The following is a description of a gene set: from publication Chen Y, Wang X (PMID 31504780) Genes predicted to be targets of miRBase v22 microRNA hsa-miR-532-3p in miRDB v6.0 with MirTarget v4 prediction scores > 80 (high confidence targets). Human Gene Set: MIR532_3P studied in species Homo sapiens, and this is the list of marker genes: PRKAR2B, TNRC6B, TRABD2B, PHF20L1, ZNF543, GALNT6, DTX4, PAPPA, SUMO1, WDR36, CYB561D1, BCL9, C1orf21, GPR182, RRM2, MYB, CYRIA, TENT4B, PAX5, SLITRK2, GLP1R, NIPBL, CHKA, RBM7, ZBTB10, MMP16, CDKL5, PSD, LBH, QKI, ATP1A2, CHD3, RPRML, NWD1, ZFP91, PDE7A, SPCS2, NFASC, KLHL12, KMT2A, FAM168A, ELAVL4 (ELAV like RNA binding protein 4), CSF1, KPNA6, EXOSC3, EFNA5, PTP4A1, ADCYAP1R1, ALCAM, TEAD3, RPL36A-HNRNPH2, TRPV3, GSPT1, IBA57, MRPL49, ZFX, LDLRAD4, TET3, TMEM100, KDF1, GUCY1A1, GALNT10, HNRNPH3, PRKCA, C22orf46P, ANKRD12, HMGA2, GSG1L, ZFP90, CLSPN, PRDM16, CLMP, WDFY3, PEA15, DDOST, SZRD1, ZGLP1, ZNF514, CYTH1, DCAF6, BET1, HNRNPH2, TSPOAP1, ELOVL3